Given this list of marker genes CRYAB, ZC3H13, ADGRA3, SFT2D3 (NCBI Gene Id 84826), AHCTF1, SKI, PRKCA, SH2D5, FAM98C, PPP6C, H3C2, PRAMEF11, EIF4H, KRCC1, MMP20, TRBC1, PHLDA3, BRD9, KCNJ3, TRIM37, ACTR3B (NCBI Gene Id 57180), KLHL32, CLLU1, HARS1, AMFR, PRKAR2A, CCNY, EGR3, RPS6KA1 (ribosomal protein S6 kinase A1), MPI, CSN2, CXCL2, NTSR1, ATMIN, GAREM1, OR5E1P, SH3GL2, TLR8-AS1, PURPL, LONRF1, LINC00052, ST20-AS1, ENSG00000255537, SLIT2-IT1, DHX38, TRA2B, TAS2R4, FETUB, PSAT1, ZNF507, TIMM23, FABP4, HPS6, SEL1L (NCBI Gene Id 6400), PPP4R1, BLOC1S3, POLR2D, GLB1L, DCAF4, NIPA2, SNX8, POC1A, PPIF, ATP12A, NTAQ1, PTPN5, CEP78, LINC01095, TCF3, SUV39H1, PSD2, SYCE1, CCNDBP1 (NCBI Gene Id 51718), RSC1A1, ZMYND11, LINC02871, FSTL4, PIK3C2B, HSD3B1, FLJ16779, NTRK2, PDE6H, CABLES2, TRAF1, PLA2G12A, CCNE1, TDRD5, GFOD1, CTC1, WNT5B, SLFN11, SUMF1, C2orf81, LIG1, LINC00310, FHL2, MCM5, ENTPD7, OLFM4, SIK2, TUBB6, UBE2Q2P13, LPAR3, ODC1, SNX30, RPL5, UBE4B, PRSS16, THBD, SLC25A35, ZFR2, ATRNL1, IFNA6, ZNF318, CBFB, SMARCE1, LRPAP1, HNRNPA0, HCN1, ZNF549, PSG1, FAM131B, SLC44A5, GRB10, ASB9, APMAP, PIK3CB, CFAP69, URB1, FITM2, CFAP157, CABP5 (NCBI Gene Id 56344), TCF7L1, SH3D19, C17orf50, SRGAP3, NR2F2-AS1 (NR2F2 antisense RNA 1), DCAF13, LHX6, PPP1R3E, PRR19, LRP12, SLC23A1, LINC00319, DHDDS, MRGPRX1, GPAT3, CERK, MYL2, FAM9A, GPATCH11, EP400P1, TRNAU1AP (tRNA selenocysteine 1 associated protein 1), RGS19, SLC26A2, RGS2, VPS36, MAFB (NCBI Gene Id 9935), SORT1, BTBD9, DUBR, KLHL35, ASB1, BTBD7, ETF1, ARB2A, WDR1, PSEN2, ACRBP, HLF, SOS2, ZBTB11-AS1, TMEM168, BCLAF1, NEPRO, EIF3B, ARIH2OS, SHOX, GOLT1A, KCNK12, SBNO1, AWAT1, ZNF473, PLD6, LETR1, BMP2K, SEPTIN12, ENSG00000291211, KLHL21, PKNOX1, NMT2, TLCD4, here is a description of the gene set: Genes down-regulated in untreated double positive thymocytes: wildtype versus ELK4 knockout. species: Homo sapiens Removal of the transcription factor SAP1a member of the Ternary Complex Factor (TCF) group of transcription factors which in conjunction with Serum Response Factor (SRF) has been shown to have a profound effect on positive selection in the thymus. When another TCF Elk1 is knocked out in mice there is no effect on positive selection unless it is on a Sap1a KO background where the phenotype is very severe. We have stimulated isolated double positive T cells (DPs) with anti-CD3 to mimic positive selection and compared basal and stimulated transcription across the four genotypes to discover the downstream targets of Sap1a involved in positive selection. from publication Costello P, Nicolas R, Willoughby J, Wasylyk B, Nordheim A, Treisman R (PMID 20554967) Human Gene Set: GSE21546_WT_VS_SAP1A_KO_DP_THYMOCYTES_DN